The following is a description of a gene set: Human Gene Set: GOBP_NEGATIVE_REGULATION_OF_PROTEIN_SUMOYLATION species: Homo sapiens Any process that stops, prevents, or reduces the frequency, rate or extent of the addition of SUMO groups to a protein., and this is the list of marker genes: MAGEA2, RELA, HMG20B, HMG20A, CTNNB1, PARK7, GNL3L, PIAS3, FSCB, CAPN3, MAGEA2B